The following is a description of a gene set: from publication MacLachlan TK, Somasundaram K, Sgagias M, Shifman Y, Muschel RJ, Cowan KH, El-Deiry WS (PMID 10644742) Genes down-regulated in SW480 cells (colon cancer with mutated p53) upon expression of BRCA1 off an adenovirus vector. Human Gene Set: MACLACHLAN_BRCA1_TARGETS_DN The breast and ovarian cancer susceptibility gene product BRCA1 has been reported to be expressed in a cell cycle-dependent manner; possess transcriptional activity; associate with several proteins, including the p53 tumor suppressor; and play an integral role in certain types of DNA repair. We show here that ectopic expression of BRCA1 using an adenovirus vector (Ad-BRCA1) leads to dephosphorylation of the retinoblastoma protein accompanied by a decrease in cyclin-dependent kinase activity. Flow cytometric analysis on Ad-BRCA1-infected cells revealed a G(1) or G(2) phase accumulation. High density cDNA array screening of colon, lung, and breast cancer cells identified several genes affected by BRCA1 expression in a p53-independent manner, including DNA damage response genes and genes involved in cell cycle control. Notable changes included induction of the GADD45 and GADD153 genes and a reduction in cyclin B1 expression. Therefore, BRCA1 has the potential to modulate the expression of genes and function of proteins involved in cell cycle control and DNA damage response pathways. studied in species Homo sapiens, and this is the list of marker genes: CD59, KRT4, CD9 (CD9 molecule), BAX, GRB2, CCNB1, RXRB, FRZB, ZYX, COL8A1, KRT5, PIN1, COL16A1, SEMA3B (NCBI Gene Id 7869), BAK1, ACTB